The following is a description of a gene set: Human Gene Set: HP_HYPERCONVEX_NAIL When viewed on end (with the digit tip pointing toward the examiner's eye) the curve of the nail forms a tighter curve of convexity. Hyperconvex nail species: Homo sapiens, and this is the list of marker genes: H3-3B, CTBP1, TP63, PIGV, RPS6KA3, ARX, POMP, ORC1 (origin recognition complex subunit 1), RECQL, ECE1, CPLX1, SIN3A, LETM1, RNU4ATAC, SETBP1, FGFRL1, PTDSS1, PLEC, TCF4, MBTPS2, NSD2, HPGD